Given this list of marker genes Eif2s1, Eif2b1, Eif2b5, Eif2s3x, Eif2b4, Eif2b3, Eif2b2, Eif2s2, here is a description of the gene set: Recycling of eIF2:GDP studied in species Mus musculus Mouse Gene Set: REACTOME_RECYCLING_OF_EIF2_GDP